Given this list of marker genes COL18A1, HBD, COTL1 (coactosin like F-actin binding protein 1), SPRR2D, KRT13, S100A9, SLPI, FAM110D, KRT16, COL1A2, PLET1, CCND1, HBA2, LTF, RHOG, S100A8, ECM1, GSTO1, here is a description of the gene set: from publication Hummerich L, Müller R, Hess J, Kokocinski F, Hahn M, Fürstenberger G, Mauch C, Lichter P, Angel P (PMID 16247483) studied in species Mus musculus Human Gene Set: HUMMERICH_MALIGNANT_SKIN_TUMOR_UP Chemically induced mouse skin carcinogenesis represents the most extensively utilized animal model to unravel the multistage nature of tumour development and to design novel therapeutic concepts of human epithelial neoplasia. We combined this tumour model with comprehensive gene expression analysis and could identify a large set of novel tumour-associated genes that have not been associated with epithelial skin cancer development yet. Expression data of selected genes were confirmed by semiquantitative and quantitative RT-PCR as well as in situ hybridization and immunofluorescence analysis on mouse tumour sections. Enhanced expression of genes identified in our screen was also demonstrated in mouse keratinocyte cell lines that form tumours in vivo. Self-organizing map clustering was performed to identify different kinetics of gene expression and coregulation during skin cancer progression. Detailed analysis of differential expressed genes according to their functional annotation confirmed the involvement of several biological processes, such as regulation of cell cycle, apoptosis, extracellular proteolysis and cell adhesion, during skin malignancy. Finally, we detected high transcript levels of ANXA1, LCN2 and S100A8 as well as reduced levels for NDR2 protein in human skin tumour specimens demonstrating that tumour-associated genes identified in the chemically induced tumour model might be of great relevance for the understanding of human epithelial malignancies as well. Genes up-regulated in malignant skin tumors (squamous cell carcinoma, SCC) formed by treatment with DMBA and TPA in the two stage skin carcinogenesis model.